Given this list of marker genes Ythdf3, Spock1, Ube2i, Npas3, Clk1, Aftph, Tcf4, Ube2e1, Ppfia2, Mknk1, Frmpd4, Api5, Rapgef1, Pls3, Grm3, Cyp2c55, Rybp, Zfp689 (NCBI Gene Id 71131), Ube2w, Fbln5, Mgat2, Rfx3, Akirin2, Sc5d, Casp12, Prkch, Zfand1, Cep290, Edem2, Depdc1a, Zgrf1, Ccdc122, Smarcad1, Kif13a, Btbd1, Rnf138, Fam204a, Nkx6-3, Setbp1, here is a description of the gene set: from publication Chen Y, Wang X (PMID 31504780) Mouse Gene Set: MIR_873A_3P species: Mus musculus Genes predicted to be targets of miRBase v22 microRNA mmu_miR_873a_3p in miRDB v6.0 with MirTarget v4 prediction scores > 80 (high confidence targets).